The following is a description of a gene set: Monocyte-derived dendritic cells (DC) and macrophages (MΦ) generated in vitro from the same individual blood donors were exposed to five different pathogens, and gene expression profiles were assessed by microarray analysis. Responses to Mycobacterium tuberculosis and to phylogenetically distinct protozoan (Leishmania major, L. donovani, Toxoplasma gondii) and helminth (Brugia malayi) parasites were examined, each of which produces chronic infections in humans yet vary considerably in the nature of the immune responses they trigger. Genes up-regulated in untreated dendritic cells (DC) versus DCs exposed to parasite L. major. from publication Chaussabel D, Semnani RT, McDowell MA, Sacks D, Sher A, Nutman TB (PMID 12663451) species: Homo sapiens Human Gene Set: GSE360_CTRL_VS_L_MAJOR_DC_UP, and this is the list of marker genes: LPCAT4, PPOX, GRIN1, ADIPOR2, USH2A, NCAPD3, LFNG, ME3, DDAH2, INPP5D, ARHGEF18, SMCHD1, FSHB, RBM6, PRIM2, AHCYL2, IL1RAP, TAX1BP3, IDH1, PTPN22, SEC23IP, E2F6, NRXN3 (neurexin 3), TMCC2, CPE, PEX10 (peroxisomal biogenesis factor 10), AGO2, ZNHIT1, RPL3, TBL2, FUCA1, TAL1, EIF2B4, DGCR2, PPFIA1, CARD8, ATF4, PRIM1 (NCBI Gene Id 5557), CRY1, NUP160, RRAGB, NCF4, PSMD9, OTC, HNRNPUL1, HOMER2, DDOST, CPVL, CPSF4, CTSB, PCCB, FRAT2, PSD, UBN1, TNFRSF10B, ANAPC15, TPP2, KDM4B, GHRHR, SGCA, KIF2C, RRM1, VGLL4, CD2AP, ELMO1, KCNS3, SLC46A3, FGR, EIF4A1, SACS, FOLR2, STX10, UMOD, POU2F1, LAPTM4A, SPRY1, PTK2, TOP6BL, MAPKBP1, PDGFRL, YWHAH, PPP3CA, KRT13, MIOS, FEM1B, PQBP1, CYP3A7, DAG1, MBTPS2, LPXN, ITGA1, EBP, RPS13, RERE, GH2, GPKOW, INVS, STS, CLEC16A, DOP1B, RAC2, CLUAP1, KIF13B, COL15A1, SLCO2B1, RETREG3, TARDBP, MEGF6, FABP3, TCERG1, HMOX1, UBE2B, DMXL1, GNL2, CLCN6, DNASE2, KDELR1, IL12A (interleukin 12A), IQCB1, CGA (glycoprotein hormones, alpha polypeptide), RPL5, MYL5, TP53BP1, FGL1, SPRY2, NPEPPS, MTCL1, HOXA11, ACLY, SMG7, PMVK, CD1C, TMEM187, ITGA3, SLIT1, CDK5, SPARC, SLC25A24, SYNGR4, COPG2IT1, NCAPH, HFE, TASOR, SLC4A4, MYO1E, LRRN2, KMO, GRPEL1, NDUFS2, LECT2, FYN, ZFHX3, KAT5, CDK20, LARP4B, SEPTIN8, SMAD7, PIK3CG, TYRO3, ATXN1, SAMHD1, INTS3, NOVA2, AHCY, ATP5MC1, S100A7, PHKA2, TLE3, ERF, VEGFC, CA4, KRT19 (NCBI Gene Id 3880), RGS10, PDE1B, PECAM1, REN, TFIP11, GPX3, HABP4, DLX2, FAM131A, CD37, CAMTA2, ADORA3, QDPR, EIF2S3, ITGB1BP1, BAD, COASY, WDR43, CD33, IGBP1, IFI16, STIP1, ARRB2, KXD1, HSD17B10, CYB561D2, ZYX